Given this list of marker genes Pdx1, Selenos, Grina, Ikbkg, Hyou1, Lrrk2, Park7, Syvn1, Txndc12, Wfs1, Tmbim6, Prkn, Ptpn1, Opa1, Xbp1, Creb3, Creb3l1, Herpud1, Bcl2l1, here is a description of the gene set: Any process that stops, prevents or reduces the frequency, rate or extent of an endoplasmic reticulum stress-induced intrinsic apoptotic signaling pathway. studied in species Mus musculus Mouse Gene Set: GOBP_NEGATIVE_REGULATION_OF_ENDOPLASMIC_RETICULUM_STRESS_INDUCED_INTRINSIC_APOPTOTIC_SIGNALING_PATHWAY